Given this list of marker genes Cdc5lrt6, Hspa8, Isy1, Prpf19, Polr2a, Xab2, Crnkl1, Cwc15, Cdc5lrt9, Rbm22, Ctnnbl1, Cdc5lrt1, Cdc5lrt4, Cdc5lrt7, Plrg1, Cdc5lrt8, Tex16, U2af2, Bcas2, Syf2, Cdc5lrt5, Cdc5lrt10, Cdc5l, here is a description of the gene set: Mouse Gene Set: GOCC_PRP19_COMPLEX species: Mus musculus A protein complex consisting of Prp19 and associated proteins that is involved in the transition from the precatalytic spliceosome to the activated form that catalyzes step 1 of splicing, and which remains associated with the spliceosome through the second catalytic step. It is widely conserved, found in both yeast and mammals, though the exact composition varies. In S. cerevisiae, it contains Prp19p, Ntc20p, Snt309p, Isy1p, Syf2p, Cwc2p, Prp46p, Clf1p, Cef1p, and Syf1p.